Given this list of marker genes SOS1, GDF7, BBS1, ZNF335, MKKS (NCBI Gene Id 8195), FGF8, FZD3, SLIT1, PAFAH1B1, PROP1, PSEN1, CDH2, AKT3, TUBA1A, PTEN, CTNNA2, GSX2, FBXW11, HESX1, FANCD2, BBS4, FZD6, FOXO3, UCHL5, SHANK3, SLC6A4, VPS51, PAX2, GBA1, WNT5A, BBS2, OTX1, SPEF2 (sperm flagellar 2), EMX1, SLC4A10 (NCBI Gene Id 57282), NF1, SMO (NCBI Gene Id 6608), here is a description of the gene set: Human Gene Set: GOBP_BRAIN_MORPHOGENESIS The process in which the anatomical structures of the brain are generated and organized. The brain is one of the two components of the central nervous system and is the center of thought and emotion. It is responsible for the coordination and control of bodily activities and the interpretation of information from the senses (sight, hearing, smell, etc.). studied in species Homo sapiens